Given this list of marker genes SLC25A5, SLC25A31, SLC35B2, SLC17A9, SLC25A25, SLC25A42, SLC25A24, SLC25A17, SLC46A2, LRRC8A, SLC25A23, SLC35B3, SLC25A4, PANX1, SLC25A41, SLC25A6, ANKH, SLC35B1, SLC19A1, here is a description of the gene set: studied in species Homo sapiens Enables the transfer of a purine ribonucleotide, any compound consisting of a purine ribonucleoside (a purine organic base attached to a ribose sugar) esterified with (ortho)phosphate, from one side of a membrane to the other. Human Gene Set: GOMF_PURINE_RIBONUCLEOTIDE_TRANSMEMBRANE_TRANSPORTER_ACTIVITY